Given this list of marker genes H1-10, VPS37A, SLC30A4, PTGS2, IGFBP7, CKAP2 (cytoskeleton associated protein 2), RAD51, ITGAE, NPAS1, MKNK1, CENPA (NCBI Gene Id 1058), BAG2, HCN2, AKR1B15, SLC31A1, GJB5, NUSAP1, KCNJ3, RRM2, CDCA8, TFAM, XRCC1, HES2, ASF1A, GART, ELOVL6 (NCBI Gene Id 79071), RGCC, FUS, ITM2A, ATP5IF1, SNHG6, LUM, PFN1, MTR, PRIM1, IGFBP2, LAMTOR1, NCAPH, DHCR24, CCR7 (C-C motif chemokine receptor 7), CDC45, SOX4, SLC4A1, EGFR, LSM7, ATF5, RET, POLE2, S1PR2, LTBP1, CYP51A1, FGF13, AHCY (adenosylhomocysteinase), PSPH, ACKR1, CCNB2, CIT, EZH2, METTL8, DMPK, USP3, POLA2, PLA2G12A, ALYREF, HOXA4, PDX1, KIF22, ID3, CDCA3, CCNA2, HOXA7, CDC25C, VCAN, DNAJC9, MYC, PLP2, MAD2L1, TK1, MRPL27, EVX2, LAMA4, TRPC4, ORC6, TENM2, PRC1, TUBB, LAMB3, HEMGN, HMGCR, SDC1, SRCIN1, LPL, KIF20A, CDK1, CCDC28B, FABP5, TPD52L1, PCDH12, ACTN1, AIRE, PLAUR, RGS10 (NCBI Gene Id 6001), RBP1, ATOH7, CD8A, CRCT1, DEGS2, APEX1, P3H3, CCT6A, H3-4, CHEK1, HSDL2, APOF, CDC20, TUBA1A, PTOV1, SGK1, ACTN2, AURKB, ALCAM, SQLE, PLG, BRCA2, SLC26A1, G0S2, PLAC8, CDH6, CKS1B, NUDT1, MYL11, CDKN2A, EMP3, TLX3, KIF4A, BIRC5, MRPL54, F12, NCBP1, NCKAP1, EXO1, TNFAIP8L1, TLE1, TULP3, RAB20, LAG3, LAMA2, STMN1, PPA1, SURF2, GAS8, RANBP1, TIPIN, SELL, PCNA, SLC46A1, E2F8, CDC6, DIAPH3, NFE2, FZD6, S1PR1, CACNA2D3, KIF23, NDC80, CENPK, SHE, KPNA2, IGFBP1, TDRP, USP22, CD8B, IL9, NOS3, CDT1, PRKCZ, TOP2A, DLX6, SLC25A4, HUS1, UTF1, MAP4K4, TCF7, CRIP1, SH3PXD2A, COL4A1, DRC1, COL1A2, NSG2, RPS26, ANLN, PARM1, UHRF1, RACGAP1, UCP1, PCLAF, NTHL1, H2AJ, SOCS3, PDLIM1, here is a description of the gene set: Genes up-regulated in macrophages: resting differentiated versus alternatively activated M2. species: Homo sapiens Human Gene Set: GSE32164_RESTING_DIFFERENTIATED_VS_ALTERNATIVELY_ACT_M2_MACROPHAGE_UP from publication Pello OM, De Pizzol M, Mirolo M, Soucek L, Zammataro L, Amabile A, Doni A, Nebuloni M, Swigart LB, Evan GI, Mantovani A, Locati M (PMID 22067385) In response to microenvironmental signals macrophages undergo different activation, indicated as classic/M1 and alternative/M2 polarization. C-Myc transcription factor could be an essential player in M2 polarization. Functional relevance of c-Myc in M2 macrophage biology is investigated by evaluating the effect of 100-58F4, on the transcriptional profile induced on human macrophages by IL-4.